The following is a description of a gene set: Enamel hypomineralization A decreased amount of enamel mineralization. Hypomineralized enamel has a brown discoloration and brittle aspect. species: Homo sapiens Human Gene Set: HP_ENAMEL_HYPOMINERALIZATION, and this is the list of marker genes: AMTN, WDR72, KLK4, PHEX, ENAM, DIAPH1, RELT, DLX3, ODAPH, GPR68